The following is a description of a gene set: from publication Kim HS, Kim MS, Hancock AL, Harper JC, Park JY, Poy G, Perantoni AO, Cam M, Malik K, Lee SB (PMID 17430890) Genes down-regulated in UB27 cells (osteosarcoma) at 12 hr after inducing the expression of a mutated form of WT1. Human Gene Set: KIM_WT1_TARGETS_12HR_DN studied in species Homo sapiens The Wilms' tumor suppressor gene (WT1) encodes a zinc finger transcription factor that is vital during development of several organs including metanephric kidneys. Despite the critical regulatory role of WT1, the pathways and mechanisms by which WT1 orchestrates development remain elusive. To identify WT1 target genes, we performed a genome-wide expression profiling analysis in cells expressing inducible WT1. We identified a number of direct WT1 target genes, including the epidermal growth factor (EGF)-family ligands epiregulin and HB-EGF, the chemokine CX3CL1, and the transcription factors SLUG and JUNB. The target genes were validated using quantitative reverse transcriptase-polymerase chain reaction, small interfering RNA knockdowns, chromatin immunoprecipitation, and luciferase reporter analyses. Immunohistochemistry of fetal kidneys confirmed that a number of the WT1 target genes had overlapping expression patterns with the highly restricted spatiotemporal expression of WT1. Finally, using an in vitro embryonic kidney culture assay, we found that the addition of recombinant epiregulin, amphiregulin, CX3CL1, and interleukin-11 significantly enhanced ureteric bud branching morphogenesis. Our genome-wide screen implicates WT1 in the transcriptional regulation of the EGF-family of growth factors as well as the CX3CL1 chemokine during nephrogenesis., and this is the list of marker genes: IL18, SMURF2, GTF2F2, MYBBP1A, BMAL2, POLR2D, LRP8, INHBA, NSDHL, CRIM1 (cysteine rich transmembrane BMP regulator 1), TFB2M, ZNF217, PLK2, SMUG1, RAP2C, TGFBR2 (transforming growth factor beta receptor 2), MAGOH, CTBP2, ZFP36L1, MTAP, YTHDF2, FXN, EXT1, NNMT, DLC1, SPTLC2, IGFBP7, ZBED4, CCN2, SSH1, SZRD1, CALD1, BCL2A1, CCND1, MRPL19, CASP4, MYC, RHOBTB3, RIMS2, STEAP1, ELK3, TRIAP1, RWDD1, SRSF7, NRG1 (neuregulin 1), CORO1C, CYP24A1, CORO2B, YY1AP1, PDF, GRSF1, RPL7P27, LIMCH1, HAPLN1, RHOG, FAM3C, NADK (NCBI Gene Id 65220), PUS1, UCHL3, CBX3, FEN1, POGK, SEMA3C, ARFRP1, DDX18, LSM5, NR2F2, ANP32A, MCL1, PTPN7, PNN, PCLO, TIMM13, HMGA2, NAP1L1, PPP1CB, SRSF2, BDNF, ASPH, WASL (NCBI Gene Id 8976), SOD2, ELF5, REXO2, NFKB1, LAMC2, TAF1D, OGFR, DUSP7, RPL29P7, ZC3H15, CDV3, COX7A2, PLEK2, NOP16, DNAAF1, RBM14, CD44, JPT1, SMAGP, THBS1, ZFP69B, NDUFC2, PFDN2, APBB2, AMIGO2, CUL4A, TUFT1, EGFR, MOB1A, C11orf68, PLSCR1, ZAP70, ATF1, WNT5B, PLAC8, MAN2A1, KITLG, HOXA10, CEACAM7, BBS4, TMED2, FLRT2, KLHL23, RIOX2, NF2, NOP56, CTNNA1, RRS1, ARHGEF40 (Rho guanine nucleotide exchange factor 40), PPIG, GPRC5A, TSR3, GADD45B, TMC5, PTPN11, CDK5R1, CD163, MIR3648-1, BAZ2B, POLR3E, ACOT2, CCN1, ZNF148, TNFAIP1, PMEPA1, RND3, SMAD7, FBXL6, ST6GALNAC5, ESM1, GNL3, DBF4, METTL13, FOXD1, POLR3K, GP1BB, OLR1, SYNGR2, TADA2A, LSM4, TMEM45A, ANKRD55, RBM25, PALM2AKAP2, TRA2B (NCBI Gene Id 6434), GLS, IL2RB, DEDD, MAP4K5, AMH, CCNE2, ASB1, KBTBD11, HNRNPAB, RPS2, VMP1, TMPO, IGSF3, PLOD2, TCP11L1, RMND5B, LAMB1, TUBB2A, SYNCRIP, SCG5, CGB3, LAT2, ZFAND5, RAP1A, HERPUD1, RPS6, SDHB, AIMP1 (aminoacyl tRNA synthetase complex interacting multifunctional protein 1), NEDD9, AEN, MSANTD2, RFTN1, CHP1, MANF, SFSWAP, DUSP1, NOLC1, RBFA, ITGBL1, HRC, CAMK2N1, ACKR3, CLN5, ADK, ARMC8, CLCC1, MRPL13, IGF2BP3, TP53TG1, EZR, ETS1